The following is a description of a gene set: Human Gene Set: GOBP_NEGATIVE_REGULATION_OF_CELL_FATE_COMMITMENT Any process that stops, prevents or reduces the frequency or rate of cell fate commitment. Cell fate commitment is the commitment of cells to specific cell fates and their capacity to differentiate into particular kinds of cells. Positional information is established through protein signals that emanate from a localized source within a cell (the initial one-cell zygote) or within a developmental field. studied in species Homo sapiens, and this is the list of marker genes: JAK3, LOXL3 (NCBI Gene Id 84695), MESP1, TBX21, HES1, SPDEF, CD69, LGALS1, FZD7, STAT5A, SFRP2, TNFSF18, SOSTDC1, DKK1, NKX6-2